Given this list of marker genes Irs1, Atp6v0a1, Atp6v1g2, Them4 (thioesterase superfamily member 4), Atp6v1c2, Shc1, Tlr9, Atp6v1e2, Fgf22, Fgf4, Atp6v1a, Atp6v1g3, Atp6v0d1, Ctsd, Ins2, Fgf6, Pik3r2, Grb2, Fgf20, Fgf10, Fgf23, Fgf2, Ptprf, Atp6v1f, Atp6ap1, Fgf7, Flt3l, Fgf16, Fgf17, Ptpn1, Fgf5, Atp6v0e, Tcirg1, Atp6v0e2, Pdpk1, Klb, Pik3cb, Mapk3 (NCBI Gene Id 26417), Irs2, Fgf8, Atp6v0c, Ins1, Fgf1 (fibroblast growth factor 1), Atp6v1d, Fgf15, Frs2, Kl, Gab1, Fgfr1, Pik3c3, Atp6v0a4, here is a description of the gene set: part of: Signaling by Receptor Tyrosine Kinases species: Mus musculus This event has been computationally inferred from an event that has been demonstrated in another species.<p>The inference is based on the homology mapping from PANTHER. Briefly, reactions for which all involved PhysicalEntities (in input, output and catalyst) have a mapped orthologue/paralogue (for complexes at least 75% of components must have a mapping) are inferred to the other species. Reactome Pathway: Signaling by Insulin receptor electronically inferred by orthology from the curated human pathway